The following is a description of a gene set: Any process that modulates the frequency, rate or extent of the chemical reactions and pathways involving any hormone. species: Homo sapiens Human Gene Set: GOBP_REGULATION_OF_HORMONE_METABOLIC_PROCESS, and this is the list of marker genes: DGKQ, DUOXA2 (dual oxidase maturation factor 2), ARNT, EGR1, NR5A2, LHCGR, DUOXA1, AKR1C3, DAB2, RDH10, HPN, ZMPSTE24, GNB3, PDE8B, ATP1A1, NR3C1, GATA3, STUB1, CLCN2, GAL, BMP2, DKK3, POR, ADM, STC2, TCF7L2, FFAR3, WNT4, H6PD, BMP6, PAX8, PRMT3, SLCO1C1, HIF1A, BMP5, FSHR, REST